The following is a description of a gene set: The process whose specific outcome is the progression of lymph nodes over time, from their formation to the mature structure. A lymph node is a round, oval, or bean shaped structure localized in clusters along the lymphatic vessels, with a distinct internal structure including specialized vasculature and B- and T-zones for the activation of lymphocytes. studied in species Mus musculus Mouse Gene Set: GOBP_LYMPH_NODE_DEVELOPMENT, and this is the list of marker genes: Tnfsf11, Ltbr, Ikzf1, Ltb, Spns2, Flt3, Cd248, Nfkb2, Ccr7, Tox, Id2, Pdpn, Ripk3, Rc3h2, Ccl21a, Cxcr5, Nkx2-3, Nfkb1, Polb, Fadd, Rorc, Jak3, Lta, Traf3ip2, Rcbtb2, Tlx1, Il15 (interleukin 15), Il7r, Rc3h1, Tnfrsf11a, Cd2ap, Cxcl13, Tgfb1